Given this list of marker genes CYP4F8, CYP4F12, CYP4F2, CYP4A22, CYP4A11, here is a description of the gene set: Catalysis of the reaction: octane + reduced rubredoxin + O2 = 1-octanol + oxidized rubredoxin + H2O. studied in species Homo sapiens Human Gene Set: GOMF_ALKANE_1_MONOOXYGENASE_ACTIVITY